The following is a description of a gene set: species: Homo sapiens Goals/objectives: to identify various gene expression in B cell subsets derived from human PBMC and cord blood from publication Suryani S, Fulcher DA, Santner-Nanan B, Nanan R, Wong M, Shaw PJ, Gibson J, Williams A, Tangye SG (PMID 19965666) Human Gene Set: GSE17186_BLOOD_VS_CORD_BLOOD_CD21HIGH_TRANSITIONAL_BCELL_DN Genes down-regulated in transitional CR2 high B lymphocytes versus those from cord blood., and this is the list of marker genes: NCEH1, IL6ST, IDNK, RFXANK (regulatory factor X associated ankyrin containing protein), PSTK, ARV1, ARL2BP, ZNF526, BTBD8, GALNT6, RAB23, ADSS2, BCL9L, PCBP4, AFP, SLC16A10, MAT2B, GPR83, ADAMTS10, ZAP70, SCML4, ARAP2 (NCBI Gene Id 23278), ARID5B, LTA, KLK8, ZSCAN25, PDE6G, MEIS3, FAS, PNKP, ADAMTS6, TP53I11, GLDC, GBP2 (guanylate binding protein 2), PECAM1 (platelet and endothelial cell adhesion molecule 1), GGT1, LMBR1L, MGAT5, ATP13A5, OXR1 (NCBI Gene Id 55074), RPL35, GOLM1, DOCK2, RCAN3, LRRC75B, CEP97, RARG, IRF6, RNASEH2C, ARHGAP45, SLC20A1, ABCB9, BMAL1, PRKAG1, NUDT16L1, TRAF3IP3, PDCD4, RRM2B, POLR3D, CD7, GNB1L, INPP5B (inositol polyphosphate-5-phosphatase B), MACROD1, PYROXD1, RTF1 (NCBI Gene Id 23168), CCS, MTMR3, DUSP11, KCNH2, ADPRM, TP53I13, MYH9, GRAMD1A, MSN, GRAMD1B, ITGB5, ACP5, DNM2, RFFL, SMPD5, GRK6, GGT7, NOP10 (NOP10 ribonucleoprotein), KCNMB4 (NCBI Gene Id 27345), CACNA2D4, USP24, CERS4, ALDH6A1, SASH3, HEMK1, STING1, TACC2, IGHM, RHOF, ENTREP1, FRMD6, DDX24, ULK1, ITM2A, CDKAL1, AFF3, RFTN1, LPP-AS2, STAT5B, PRKCZ, TMEM50A, RPL5, ZNF175, ADGRL1, CDKN2D, AP3M2, SMOX, TIGD2, CYTH1, FAM3C, RNF38, LFNG, SFMBT2, CHST10, SPO11, MADD, GTDC1, NOCT, DCAF1, RRAS2, FETUB, RASA3, DSEL, PSIP1, HVCN1, INPP5F, ZC3HAV1, LELP1, S100A10, CD72, CBR1, FYN, GPN3, FOXO1, SLC12A6, MTG2, DDX6, SKI, APRT, RUNDC3B, AVEN, KDSR, RAP2B, AOPEP, BCDIN3D, XKRX, CHD2, SLFN13, MRPL24, ACVR1B, STX1A, PANX1, DPH2, CD53, PSENEN (presenilin enhancer, gamma-secretase subunit), ANKRD26, ADD1, ZNF280B, TPRG1L, ST6GALNAC2, DENND2D, XKR6, ADD3, GUCA1B, CCDC82, SIGIRR (single Ig and TIR domain containing), FBXL20, SLFN12L, LRRC8A, PCMTD1, TREML2, RHBDL3, HELZ, CDH23, IGFLR1, C9orf152, IGF2BP2, ZNRF1, SLC26A2, HELZ2, GUCD1, SYTL1, PAPOLG, POU6F1 (POU class 6 homeobox 1), TEX264, PPARGC1B, ZMYM2, ARMC3, KLHL22, RIGI, SELL, TBCEL, AKAP12, TNIP1, PPIL3